Given this list of marker genes COL5A2, FN1, GRB2, ITGA4, MIR1-1, TLX2, EXT2, MIXL1, SRF, GATA6, MMP2, TXNRD1, LAMB1, KIF16B, CDC73, SMAD3, MACROH2A1, ITGB4, NF2, WLS, ATOH8, NODAL (nodal growth differentiation factor), COL6A1, APELA, FGFR1, MYH9, TWSG1, ITGAV, BMP4 (NCBI Gene Id 652), ITGA8, COL11A1 (NCBI Gene Id 317718), DUSP5, FGFR2, MMP14, SMAD1, EOMES, TAL1 (TAL bHLH transcription factor 1, erythroid differentiation factor), HNF1B, COL8A1, LEF1, KDM6B, TBX6, NANOG, LAMB3, SOX2, SIX2, TBX19, AHDC1, MSGN1, HMGA2, BMPR2, MAP2K1, EPB41L5, ARMC5, FOXC2, ACVR1, PRKAR1A, RTF1, WNT11, ITGA2, MIR200C, GJA1, MESP1, HOXA11, SETD2, COL4A2, MIR145, WNT3A, COL5A1, GPI, BMPR1A (NCBI Gene Id 8035), VTN, MESP2, COL12A1, TBXT, INHBA, DUSP1, POFUT2, KLF4 (NCBI Gene Id 9314), ETV2, COL7A1, WNT5A, CTNNB1, BMP7, PAX2, FZD7, DUSP4, EYA2, SOX7, TBX20, DUSP2, MMP15, BRD3, SMAD2, NR4A3, SOX17, HSBP1, SFRP2, AXIN1, EYA1, LHX1, LAMA3, NR0B1, PAF1, MIR150, ITGB3, EPHA2, ITGB1, SNAI1, ITGA5, LEO1, DKK1, CTR9, TAF10, ELF5, POU5F1, CRB2, SCX, NOG, ITGA7, ETS2, PRKACA (NCBI Gene Id 5566), ITGA3, ITGB2, HAND1 (NCBI Gene Id 9421), MMP9, EXOC4, FOXF1, MMP8, TRIM15, ENSG00000285205, WNT3, FOXC1, ITGB5, here is a description of the gene set: Human Gene Set: GOBP_FORMATION_OF_PRIMARY_GERM_LAYER studied in species Homo sapiens The formation of the ectoderm, mesoderm and endoderm during gastrulation.